The following is a description of a gene set: studied in species Mus musculus Mouse Gene Set: GOBP_RECEPTOR_DIFFUSION_TRAPPING The process by which a membrane receptor, diffusing freely within the plasma membeane, becomes trapped in some plasma membrane region. This can happen when a receptor bind, directly or indirectly, to some component of the underlying matrix., and this is the list of marker genes: Tspan9, Cacng4, Cacng3, Dlg4, Camk2a, Shisa6, Cacng2, Cacng8, Cacng5, Itgb1, Itgb3, Zdhhc2, Slc12a5, Rdx, Cacng7